Given this list of marker genes ATP6V0A2, SCN4A, MAP3K20, CAV3, PMP22, TBX5, SALL4, MYL2, FBN2, TPM3, FLVCR2, HACD1, ALG9, FLNA, HBB, TGFBR1, ACTA1, MYMK, ITGA7, SELENON, COLEC11, MAP3K7, TPM2 (tropomyosin 2), GLE1, RBM8A, here is a description of the gene set: Human Gene Set: HP_HYPOPLASIA_OF_THE_MUSCULATURE Underdevelopment of the musculature. species: Homo sapiens Hypoplasia of the musculature